Given this list of marker genes C4BPA, MFSD4A, FAM72A, LPGAT1, IPO9-AS1, RNU2-19P, FLVCR1, MIR29B2CHG, LINC02769, ENSG00000283044, KRT8P29, ST13P19, LARP7P1, PPFIA4, ETNK2, PTPN7, HSD11B1, PLEKHA6, ERLNC1, SNORA70, LINC02942, MFSD4A-AS1, RNU6-89P, NUAK2, MIR181B1, TNNT2, TIMM17A, RPS10P7, ADIPOR1, CYCSP4, ZBED6, KISS1, AVPR1B, CDCA4P3, REN, NEK2-DT, RPL13AP8, AVPR1B-DT, RAB7B (NCBI Gene Id 84855), INTS7, SHISA4, RPL7AP20, MGAT4FP, KCNH1, SNRPGP10, LAX1, SLC26A9, ENSG00000212187, RPL22P4, ENSG00000306579, MIR1231, MIR29B2, MIR6769B, CTSE, ELF3-AS1, ENSG00000299121, SNORA70H, PROX1-AS1, CRIP1P3, LINC01353, MROH3P, CR1, NAV1 (NCBI Gene Id 89796), PROX1, COX7CP2, PLXNA2, MIR205, TUBA5P, RPL21P28, LINC01717, MIR6740, RPL34P6, HSPE1P6, LRRN2, RPL13AP11, MIR6739, PRELID1P5, MYOG, KDM5B, BPNT2P1, RCOR3, CNTN2, LINC01735, KLHDC8A, IGFN1, DTL, NSA2P1 (NSA2 pseudogene 1), PIGR, LINC02608, NENF, SNX25P1, TMEM183A, CD46P1, LEMD1-AS1, MIR181A1HG, SNORA16B, PIK3C2B, LINC00862, RNA5SP534, LEMD1-DT, NSL1, ZC3H11A, IPO9 (importin 9), PCAT6, RNU6-609P (RNA, U6 small nuclear 609, pseudogene), CR1-AS1, MGAT4EP (MGAT4 family member E, pseudogene), IL19, RD3, MDM4, TFDP1P1, TNNI1, PPP2R5A, RAB29, BATF3, SLC30A1, SYT14, PACC1, CHIT1, RN7SL344P, SOX13, IPO8P1, CACNA1S, GPR37L1, LAMB3, ADORA2BP1, ADORA1 (adenosine A1 receptor), EEF1A1P44, IKBKE, PPP1R12B, CAMK1G, GPR25, C4BPB, NUCKS1, ATF3, ENSG00000286383, ASCL5, ENSG00000252692 (novel transcript), RPL10P4, C1orf74 (NCBI Gene Id 148304), LINC00538, LGR6, ENSG00000287445, LINC01696, HNRNPA1P59, RNU6-487P, LEMD1, TMEM9, RPL35AP5, LINC02771, SLC45A3, ENSG00000288644, PKP1, LINC00303, RN7SKP98, HSD11B1-AS1, RNU6-704P, DDX59-AS1, HHAT, NEK2, RNA5SP75, FLVCR1-DT, LINC01774, IL10, RHEX, NPM1P40, RBBP5, LPGAT1-AS1, KCNH1-IT1, G0S2, MIR4260, CR2, GARIN4, SYT2-AS1, ANGEL2 (NCBI Gene Id 90806), TRAF3IP3, FDPSP8, LINC02775, PTPRVP, MIR135B, LMOD1, ATP5MC2P1, RNU6-570P, RABIF (NCBI Gene Id 5877), YOD1, RPL31P13, RNU6-418P, RNU6-716P, LINC02767, TMCC2, RPL23AP18, PPP1R15B-AS1, CCNQP1, ACTG1P25, LAD1, VASH2, SNORA72, MIR205HG, ENSG00000282849, ATP2B4, CBX1P3, CDK18, MIR29C, FMOD (NCBI Gene Id 2331), CDCA4P4, TRAF5, IL24, RPS26P13, RNPEP, DSTYK, SLC25A39P1, ENSG00000305491, PM20D1-AS1, DYRK3, RNU5A-8P, UBE2T, LINC02773, ELF3, ENSG00000304011, UTP25 (NCBI Gene Id 80064), IL20, SRGAP2, C1orf116, SNRPE, DDX59, LINC01698, ELK4, INAVA, CR1L, MIR181A1, CD46, CD34, KIF21B, SYT2, NR5A2, NFASC, PFKFB2, ENSG00000287354, LINC00467, MIR3122, PPP1R15B, EIF2D, SLC41A1, FCMR, RNU6-778P, LINC01221 (long intergenic non-protein coding RNA 1221), CSRP1, SERTAD4-AS1, SNORA77, BTG2, PM20D1, C4BPAP1, PHLDA3, RASSF5, IRF6, C4BPAP2, RPL21P19, ENSG00000298838, BTG2-DT, MAPKAPK2, ZNF281, RPS6KC1, SPATA45, MIR5191, BLACAT1, LINC00628, KIF14, TMCC2-AS1 (NCBI Gene Id 101929459), RPL23AP16, CAMSAP2, CSRP1-AS1, IKBKE-AS1, RPS27P8, SERTAD4, LINC02789, FCAMR, CYB5R1, RNU6-501P (RNA, U6 small nuclear 501, pseudogene), RPL17P8, KLHL12, CD55, RFKP5, LINC01222, CHI3L1, OPTC, GOLT1A, SMYD2, TATDN3, LINC01740, RNA5SP74, ARL8A, PRELP, ENSG00000234132, MYBPH, DYRK3-AS1, ARPC3P2, NTRAS, TMEM81, here is a description of the gene set: Human Gene Set: chr1q32 species: Homo sapiens